The following is a description of a gene set: Human Gene Set: HP_PREMATURE_RUPTURE_OF_MEMBRANES Premature rupture of membranes (PROM) is a condition which occurs in pregnancy when the amniotic sac ruptures more than an hour before the onset of labor. Premature rupture of membranes studied in species Homo sapiens, and this is the list of marker genes: RRAGC, MED12, COL1A1, COL5A2, SERPINH1, LEMD2, COL5A1, PLOD1, FGFR3, RSPRY1, COL3A1, DEF6, ADNP, ZMPSTE24, ADAMTS2, ATP6V0A2, RBM10